The following is a description of a gene set: Mouse Gene Set: GOMF_LIGAND_GATED_CALCIUM_CHANNEL_ACTIVITY Enables the transmembrane transfer of a calcium ions by a channel that opens when a specific ligand has been bound by the channel complex or one of its constituent parts. species: Mus musculus, and this is the list of marker genes: Ryr1, Ryr3, Grik2, Trpv1, Scnn1b, Mcoln2, Grin2b, Grin2c, Tpcn2, Mcoln1, Grin2d, Scnn1a, Pkd2, Grik1, Grin1, Tpcn1, Itpr1, Trpm8, Trpm2, Mcoln3, Ryr2, Rasa3, P2rx4, Trpa1, P2rx1, Itpr2 (NCBI Gene Id 545892), Gria3, Gria1, Bnip1, Itpr3, Scnn1g, Grin2a, Grik3